The following is a description of a gene set: from publication Chen Y, Wang X (PMID 31504780) Human Gene Set: MIR4755_5P Genes predicted to be targets of miRBase v22 microRNA hsa-miR-4755-5p in miRDB v6.0 with MirTarget v4 prediction scores > 80 (high confidence targets). studied in species Homo sapiens, and this is the list of marker genes: NRBF2, CREB5, RTKN2, EPHB2, ROR1, ITGB1, SH2B3, CNKSR3, RNF169, WDR26, LEPROT, TAOK1, UEVLD, MAP1B, ABRAXAS2, ZDHHC14, ATXN2, NXPH1, POU3F2, MEIS2, VWA8, BICC1, MTMR12, WNT9B, MAPRE2, SLC28A3, HAPLN1, PHOX2B, GAD1, GCNT2, POM121, CHD5 (NCBI Gene Id 26139), MON2, FGFR2, DLG1, EPHB6, GNAQ, RREB1 (NCBI Gene Id 6239), FOXC1, ONECUT2, IRF2, CACNA1C, RASL10A, ANGPT1, GSTM3, KCNK9, EFNA5, SOX14, MOCS1, BCL2L2, SLC38A9, MRPS17, ELAVL3, C18orf32, SLC16A6, BIN1, KCNMA1, BPNT2, ACADL, SH3TC2, BMPR1A, SEC24D, FRMD4A, FRS2, ELAVL2, BCL11A, NAA15, SAMD4A, CLCN6, RHOBTB3, MAPK9, BIRC6, HAPSTR1, GSPT1, SH3PXD2A, DNAJC13, TMA16, KLF11, DGKG, TENT5A, PTPRD, CES2, MGAT3, SNX13, ATL2, EVC2, UBR2, RBM41, PIAS1, SNX18, MTCL1, ITPR1, FBN2, EBF2, NUCKS1, RPS6KA5 (ribosomal protein S6 kinase A5), NR5A2, ENTHD1, TSPAN8, PIK3CB, AHSA2P, PTGR3, FBXL22, FLT1, JARID2, RSPO4, CCDC117, HMGN4, NRG3 (neuregulin 3), ZNF300, RTL8B, CDKN2B, TMEM127, SPOP, TENM1, CALCRL, KDM5A, TFAP2A, FAM98B, NCOA7, KXD1, SAMD5, HNRNPA2B1, NEXMIF, GTF3C3, ATP8A2, RGL1, ZBTB20, C2orf68, KIF1B, SUN1, CCNJ, SIRT1, C2CD2, CHCT1, ACSM2A (acyl-CoA synthetase medium chain family member 2A), DAZL, KLF3, ENTPD7, TSPAN13, WWC3, CCND1, PPIC, ZNF549, GPBP1L1, PLEKHM3, ATP10B, DR1, GOSR2, POLE3, ZEB1, EFNB3, PI4KB, A2ML1, CAPRIN1, C1orf185, PID1, ACVR2B, STXBP5L (syntaxin binding protein 5L), MPP7, HYCC1, RUSC1, CCND2, SGIP1, ARCN1, HMGA2, TOMM40L, TCF12, SLC7A14, YPEL2, CELF2, ALDH6A1, SNAP47, CHN2, CDH11, KLHL29, HOXD1, SLITRK4, TMEM64, INO80D, PLXNA2, FRAS1, RFX7 (regulatory factor X7), AK2, LARP4B, SZRD1, DTX4, TIFA, PROX1, ARHGEF33, RETSAT, BHLHE22, ANO6, MINDY2, ITIH5, ICE2, CCDC25 (coiled-coil domain containing 25), ELF4, RIMS2, SLC16A12, SMIM13, RPRD2 (NCBI Gene Id 23248), HCAR2, YPEL4, FMO5, SORT1, CDK12, PTPRT, VPS37B, BCL7A, SGCD, TMOD3, NIPA2, N4BP2L1, IL6R, MTCH2, ZNF148, TNRC6B, TUT7, TUT4, GNG12, SEPTIN11, AMER1, MTMR7, ZC3H7A, LARP6, CAMK2D, ZNF605, COX5A, MLLT3, C9orf40, SLC37A3, IKZF2, SASS6, HSPH1, HOOK3, GLIS3, AP2A2, TGFBR2, ATF2, NR3C1, ZNF740, CAMK1D, DPF1, DNAAF9, NRP1, C14orf28, ACSL4 (acyl-CoA synthetase long chain family member 4), PGGT1B, SHC1, JAK2, GABBR2, KSR2, TRIM2, PPP1R9A, HS6ST3, WDFY2, FUT9, EPHA5, SEC61A2, RAB22A, NBR1, RAB10, CLN8 (CLN8 transmembrane ER and ERGIC protein), ZCCHC24, IRF2BP2, ZMYND8 (NCBI Gene Id 55497), KLHL6, CTIF, LPP, ZBTB7C, IL33, NTRK2, FLVCR1, TRIM44, IGFBP5, GDF6, GOLGA5, ZNF268, BCL2, ADGRL3, MAP3K2, DMTF1, AFAP1, M6PR, PTP4A1, TOX3, PLXDC2, LRP2, DCN, FHIP1B, TET2, FAM13C, CCNY, EPHA4, CENPA, PPARGC1A, CCDC120, UBA6, FGF18 (fibroblast growth factor 18), AP1S2, TRPS1, ZNF266, RIN3, MCOLN1, HAS2, HNRNPUL1, PDGFRB, ARL6IP5, B3GNT5, CDYL2, MMP16, SDHD, IPO8, CRACD, ESRRG, PLCH1, BACE2 (NCBI Gene Id 25825), ARMC8, EZR, TRIM71, IL11, RINT1, AP3M1, RAD21, PREPL, SKI, EGFLAM, SPCS3, SOCS4, RPL17-C18orf32, TMEM178B, TMEM213, CTDSPL2, EPHA7, BPIFC, RAB40B, SLC2A13, CIMAP2, NAA40, ANKRD13A, ELAVL4, SLC19A2, MAN2A2 (NCBI Gene Id 55485), BCL11B, C2orf76, HNF4G, ERC1, PEX19, MYCT1, RNLS (renalase, FAD dependent amine oxidase), LIG3 (NCBI Gene Id 3980), MYADML2, ODR4, PTPRR, IGF2R, ZNF704, TMEM135, USP14, LSAMP, MLXIP, SPRY3, DVL3, TXNDC5, EDEM3 (NCBI Gene Id 87240)